Given this list of marker genes Sh2b3, Ubb, Csk, Socs2, Sla, Rps27a, Cbl, Flt3l, here is a description of the gene set: electronically inferred by orthology from the curated human pathway part of: FLT3 Signaling Reactome Pathway: Negative regulation of FLT3 This event has been computationally inferred from an event that has been demonstrated in another species.<p>The inference is based on the homology mapping from PANTHER. Briefly, reactions for which all involved PhysicalEntities (in input, output and catalyst) have a mapped orthologue/paralogue (for complexes at least 75% of components must have a mapping) are inferred to the other species. studied in species Mus musculus